The following is a description of a gene set: Mouse Gene Set: GOBP_RENAL_SYSTEM_VASCULATURE_DEVELOPMENT The process whose specific outcome is the progression of vasculature of the renal system over time, from its formation to the mature structure. studied in species Mus musculus, and this is the list of marker genes: Foxc2, Ednra, Edn1, Notch1, Angpt2, C3ar1, Cflar, Pdgfa, Notch2, Tek, Notch3, Pkd2, Bmp7, Osr1, Serpinb7, Cd34, Acta2, Nrp1, Angpt1, Pdgfb, Aqp1, Hes1, Wt1, Gpr4, Egr1, Bmp4, Itgb3, Pdgfra, Pdgfd, Il6ra, Ifng, Pdgfrb, Tcf21